The following is a description of a gene set: Any multimeric complex connected to a microtubule. species: Mus musculus Mouse Gene Set: GOCC_MICROTUBULE_ASSOCIATED_COMPLEX, and this is the list of marker genes: Nde1, Kif15, Odad1, Kif6, Kif2b, Map2, Katna1, Dync1li2, Mefv, Birc5, Aurkc, Kifc2, Dnah8, Kif17, Klc3, Ccdc65, Kif23, Dnhd1, Kif3a, Sptbn5, Kif19a, Snx4, Haus8, Dync1i2, Dnai2, Dynlt2b, Haus1, Dctn4, Kif14, Dctn6, Dnah9, Kif28, Dync1i1 (NCBI Gene Id 209813), Dnah7a, Actr1a, Klc1, Drc1, Dctn5, Kif19b, Dnah6, Borcs5, Kif22 (kinesin family member 22), Kif5c, Ccdc103, Dynlt1f, Kif21b, Actr1b, Rp1, Dynlt1a, Kif4, Dnal1, Dynlt1c, Ttbk1, Dynlt4, Kifc1, Actr10, Haus5, Hdac6, Kif20b, Haus3, Pafah1b1, Kif1a, Kif13b, Dynll1, Dnah7c, Dnah17, Klc2, Dync2i1, Fnta, Kif1c, Dnal4, Dnai7, Dynlt3, Kif18b, Dnah2, Kif16b, Nme8, Kif20a, Fntb, Dnali1, Dnah11, Kif5a, Haus6, Kif2a, Dnah10, BC048507, Kifc5b, Dnah1, Dnah12, Kif2c, Dynll2, Fbxw11, Map1s, Cfap70, Nudcd3, Kif9, Dynlrb1, Dynlt1b, Haus7, Shtn1, Lrp8, Dnah14, Ndel1, Kif1b, Katnbl1, Dctn2, Kif3b, Map1b, Klc4, Kif27, Dync1h1, Gabarap (gamma-aminobutyric acid receptor associated protein), Trim54, Dync1li1, Kifc3, Kif12, Ywhae, Dync2i2, Kif7, Dynlrb2, Dync2h1 (NCBI Gene Id 77047), Dnah7b, Disc1, Tpr, Cdca8, Dynlt2a1, Kif13a, Katnal1, Katnb1, Dctn1, Dnai1 (dynein axonemal intermediate chain 1), Aurka, Kif18a, Kif5b, Haus2, Aurkb, Haus4, Kifap3, Dnai3, Dnai4, Kif3c, Incenp, Dynlt5, Dnah5, Pea15a, Dync2li1, Map1lc3b, Dctn3, Map1a, Dnah3, Kif21a